Given this list of marker genes NAT8B, ATG2A, ULK3, TEX264, CDK5RAP3, ULK2, ULK1, UFC1, UFL1, RB1CC1, ATG9A, ATG9B, DDRGK1, STING1, RETREG1 (reticulophagy regulator 1), BNIP3, RETREG3, ATG2B, SNX7, UBA5, UFM1, RETREG2, SNX30, here is a description of the gene set: Human Gene Set: GOBP_RETICULOPHAGY species: Homo sapiens The selective autohagy process in which parts of the endoplasmic reticulum are loaded into autophagosomes, delivered to the vacuole, and degraded in response to changing cellular conditions.